Given this list of marker genes Mxd4, Dusp1, Ppp1r15a, Fos, Cxcr4, Ahnak, Klf2, Mbnl1, Rgs2, Stk17b, Hmgb2, Klf6, here is a description of the gene set: from publication Cui A, Huang T, Li S, Ma A, Pérez JL, Sander C, Keskin DB, Wu CJ, Fraenkel E, Hacohen N (PMID 38057668) Cytokines mediate cell-cell communication in the immune system and represent important therapeutic targets. A myriad of studies have highlighted their central role in immune function, yet we lack a global view of the cellular responses of each immune cell type to each cytokine. To address this gap, the authors created the Immune Dictionary, a compendium of single-cell transcriptomic profiles of more than 17 immune cell types in response to each of 86 cytokines (>1,400 cytokine-cell type combinations) in mouse lymph nodes in vivo. A cytokine-centric view of the dictionary revealed that most cytokines induce highly cell-type-specific responses. For example, the inflammatory cytokine interleukin-1β induces distinct gene programmes in almost every cell type. A cell-type-centric view of the dictionary identified more than 66 cytokine-driven cellular polarization states across immune cell types, including previously uncharacterized states such as an interleukin-18-induced polyfunctional natural killer cell state. studied in species Mus musculus Mouse Gene Set: CUI_TREG_IL18_RESPONSE_DN Genes negatively differentially expressed in cell type: Treg upon treatment with cytokine: IL-18 in mouse lymph nodes in vivo.